The following is a description of a gene set: species: Mus musculus Any process that modulates the frequency, rate or extent of early endosome to late endosome transport. Mouse Gene Set: GOBP_REGULATION_OF_EARLY_ENDOSOME_TO_LATE_ENDOSOME_TRANSPORT, and this is the list of marker genes: Nf2, Rdx, Src, Sh3glb1, Chmp3, Snx3, Map2k2, Dennd10, Snx12, Mapk3, Mapk1, Rab21, Vps11, Mtmr2, Msn, Ptpn23, Dab2, Dnajc13, Map2k1, Ezr